The following is a description of a gene set: The directed movement of an oligopeptide from outside of a cell, across the plasma membrane and into the cytosol. species: Mus musculus Mouse Gene Set: GOBP_OLIGOPEPTIDE_IMPORT_ACROSS_PLASMA_MEMBRANE, and this is the list of marker genes: Slc7a11, Slc15a3, Slc15a4, Slc15a2, Slc15a1